The following is a description of a gene set: Any process that modulates the frequency, rate or extent of the controlled release of glutamate. Mouse Gene Set: GOBP_REGULATION_OF_GLUTAMATE_SECRETION species: Mus musculus, and this is the list of marker genes: Syt4, Gabbr1, Stxbp1, Ntsr1, Grm7, Hrh3, Snca, Slc38a2, Prkg1, Adora1, Cck, Nr3c1, Dpysl2, Il1rn, Kmo, Grm2, Grin2b, Il1b, Avpr1a, P2rx7, Adora2a, Trh (NCBI Gene Id 22044), Rab3gap1 (NCBI Gene Id 69346), Npy5r, Avp, Dtnbp1, Htr6